The following is a description of a gene set: Uptake of hexoses, notably D-glucose, fructose, and galactose, into the blood by absorption from the small intestine. Human Gene Set: GOBP_INTESTINAL_HEXOSE_ABSORPTION species: Homo sapiens, and this is the list of marker genes: VIL1, CLDN2, PLS1, SLC5A1, CLDN15, SLC2A5, EZR